The following is a description of a gene set: from publication Hay SB, Ferchen K, Chetal K, Grimes HL, Salomonis N (PMID 30243574) Human Gene Set: HAY_BONE_MARROW_CD34_POS_LYMPHOID_UNK species: Homo sapiens, and this is the list of marker genes: FABP5, LDHA, KCNK9, BCAT1, GLDC, VAT1L, CAPSL